The following is a description of a gene set: Interactions between extracellular matrix (ECM) and mammary epithelial cells are critical for mammary gland homeostasis and apoptotic signaling. Interferon regulatory factor-1 (IRF-1) is a transcriptional regulator that promotes apoptosis during mammary gland involution and p53-independent apoptosis. We have recently shown that rapid cell surface tamoxifen (Tam) signaling promotes apoptosis in normal human mammary epithelial cells that were acutely damaged by expression of human papillomavirus type-16 E6 protein (*HMEC-E6). Apoptosis was mediated by recruitment of CREB-binding protein (CBP) to the gamma-activating sequence (GAS) element of the IRF-1 promoter, induction of IRF-1 and caspase-1/-3 activation. Here, we show that growth factor-depleted, reconstituted ECM (rECM), similar to Tam, promotes apoptosis in *HMEC-E6 cells through induction of IRF-1. Apoptosis was temporally associated with recruitment of CBP to the GAS element of the IRF-1 promoter, induction of IRF-1 expression and caspase-1/-3 activation. Small interfering RNA-mediated suppression of IRF-1 protein expression in *HMEC-E6 cells blocked (1) induction of IRF-1, (2) caspase-1/-3 activation and (3) apoptosis. These observations demonstrate that IRF-1 promotes rECM-mediated apoptosis and provide evidence that both rECM and rapid Tam signaling transcriptionally activate IRF-1 through recruitment of CBP to the IRF-1 GAS promoter complex. Genes up-regulated by tamoxifen in HMEC-E6 cells (mammary epithelial cells damaged by expression of HPV-16 E6). studied in species Homo sapiens from publication Bowie ML, Troch MM, Delrow J, Dietze EC, Bean GR, Ibarra C, Pandiyan G, Seewaldt VL (PMID 17016442) Human Gene Set: BOWIE_RESPONSE_TO_TAMOXIFEN, and this is the list of marker genes: IFNGR1, IRF9, IFI6, IFIT3, OAS1, IFIT2, STAT1, IFIT1, CCL5, IFI16, IRF1, OAS2, IFITM1, IFI27, IRF7, ISG15, IFI35, MX1 (NCBI Gene Id 4599)